Given this list of marker genes Lgals9, Sp100, Ifit2, Isg20, Fcgr1, Usp18, Ube2l6, Bst2, Slfn5, Ifi211, Pnp, Phf11b, Ifi209, Cxcl10, Ifit3, Slfn1, Oasl2, Mndal, Samhd1, Sdc3, Slfn2, here is a description of the gene set: from publication Cui A, Huang T, Li S, Ma A, Pérez JL, Sander C, Keskin DB, Wu CJ, Fraenkel E, Hacohen N (PMID 38057668) Genes positively differentially expressed in cell type: Monocyte upon treatment with cytokine: IFN-κ in mouse lymph nodes in vivo. Mouse Gene Set: CUI_MONOCYTE_IFNK_RESPONSE_UP Cytokines mediate cell-cell communication in the immune system and represent important therapeutic targets. A myriad of studies have highlighted their central role in immune function, yet we lack a global view of the cellular responses of each immune cell type to each cytokine. To address this gap, the authors created the Immune Dictionary, a compendium of single-cell transcriptomic profiles of more than 17 immune cell types in response to each of 86 cytokines (>1,400 cytokine-cell type combinations) in mouse lymph nodes in vivo. A cytokine-centric view of the dictionary revealed that most cytokines induce highly cell-type-specific responses. For example, the inflammatory cytokine interleukin-1β induces distinct gene programmes in almost every cell type. A cell-type-centric view of the dictionary identified more than 66 cytokine-driven cellular polarization states across immune cell types, including previously uncharacterized states such as an interleukin-18-induced polyfunctional natural killer cell state. species: Mus musculus